Given this list of marker genes TWIST2, LZTFL1, MTCL2, ELFN1, GAP43, TXNDC8, SMUG1, POU4F2, SAMD4B, AAK1, PEG10, CIMIP6, NSD1, ZNF671, LGR6, USB1, FER1L6, EFHC2, C9orf152, PHF21A, GP6, TOM1L2, MPIG6B (NCBI Gene Id 80739), NT5E, ACTR1A, C11orf91, NDRG3, GNG5, POU2F2, RANBP1, RIMS3, C12orf56, CBFA2T3, HDGFL3, DUSP8, ATP1A3, GCH1, SF3B1, TNRC6B, KRTAP4-4, GFPT2, MLX, NAT2, CASR, STAC, LILRA1, SDK1, XYLB, LSM12, ARHGAP31, PEX19, SFMBT2, RORA, TSPAN6 (NCBI Gene Id 7105), SCN7A, BASP1, PCYT1B, KLRC3, ATRAID, DVL3, PTGFRN, RNF170, CRTC1, SUMO3, STYX, TNFSF15, SPA17, SMAP2, MLEC, NMNAT2, ISL2, BTBD9, USP13, ZC4H2 (zinc finger C4H2-type containing), SMIM43, MAP1B, HNRNPU, NMBR, GNAQ (NCBI Gene Id 2776), SPRY3, LRATD2, DOCK5, KCNH7, HOXC5, KLF9, ARF3, TENT4B, C1QTNF1, ZKSCAN8, TMEM121B, CACNG3, PATE4, ATP1B2, MTA3, EPHA6, TMA7, SCUBE3, IL10, ZNF24, MAP7D1, DRICH1, SPINT1, LHFPL4, RBFA, FNDC5, NR3C1, here is a description of the gene set: from publication Chen Y, Wang X (PMID 31504780) Human Gene Set: MIR6856_5P studied in species Homo sapiens Genes predicted to be targets of miRBase v22 microRNA hsa-miR-6856-5p in miRDB v6.0 with MirTarget v4 prediction scores > 80 (high confidence targets).